The following is a description of a gene set: Mouse Gene Set: HALLMARK_PI3K_AKT_MTOR_SIGNALING species: Mus musculus from publication Howe DG, Blake JA, Bradford YM, Bult CJ, Calvi BR, Engel SR, Kadin JA, Kaufman TC, Kishore R, Laulederkind SJF, Lewis SE, Moxon SAT, Richardson JE, Smith C (PMID 30224793) Mouse genes annotated to HALLMARK_PI3K_AKT_MTOR_SIGNALING based on orthology mappings provided by the Alliance Genome Consortium, and this is the list of marker genes: Calr, Ddit3, Cab39l, Map2k6, Pten, Cfl1, Hras, Map2k3, Map3k7, Pdk1, Mknk2, Arf1, Ube2d3, Sqstm1, Cdk1, Csnk2b, Sla (NCBI Gene Id 20491), Hsp90b1, Actr3, Nck1, Eif4e, Sfn, Gngt1, Pin1, Tsc2, Grk2, Ripk1, Gna14, Ube2n, Prkar2a, Tbk1, Ngf, Ywhab, Rps6ka1, Il2rg, Mapk8, Cab39, Pik3r3, Vav3, Prkcb, Atf1, Fasl, Pikfyve, Mapk9, Ppp1ca, Rit1, Myd88, Mapkap1, Acaca, Them4, Nfkbib, Stat2, E2f1, Pitx2, Dapp1, Ptpn11, Mapk1, Cdkn1b, Akt1, Plcg1 (phospholipase C, gamma 1), Lck, Camk4, Prkag1, Rps6ka3, Traf2, Ralb, Pfn1, Arpc3, Tnfrsf1a, Adcy2, Nod1, Cltc, Trib3, Grb2, Ppp2r1b, Arhgdia, Cdkn1a, Prkaa2, Egfr, Itpr2, Rac1, Fgf17, Rptor, Actr2, Cdk2, Cdk4, Ecsit, Mapk10, Irak4, Slc2a1, Pak4, Mknk1, Tiam1, Smad2, Pla2g12a (NCBI Gene Id 66350), Cxcr4, Plcb1, Raf1, Dusp3, Gsk3b, Fgf22, Ap2m1, Akt1s1, Fgf6, Il4